The following is a description of a gene set: Genes down-regulated in comparison of untreated macrophages versus those cultured with M-CSF, IFNG and Pam3Cys (TLR2 agonist). Gene expression analysis of freshly isolated CD14+ human monocytes and monocytes cultured in the presence or absence of interferon (IFN) -gamma for 24 h and then stimulated with Pam3Cys, a Toll-like receptor (TLR) 2 ligand, for 6 h. Results provide insight into mechanisms by which IFN-gamma reprograms early macrophage differentiation and subsequent response to TLR ligands. Human Gene Set: GSE11864_UNTREATED_VS_CSF1_IFNG_PAM3CYS_IN_MAC_DN species: Homo sapiens from publication Hu X, Chung AY, Wu I, Foldi J, Chen J, Ji JD, Tateya T, Kang YJ, Han J, Gessler M, Kageyama R, Ivashkiv LB (PMID 18976936), and this is the list of marker genes: ISOC1, JPT2, CLDND1, MMAB, RBM19, ZNF175 (NCBI Gene Id 7728), DAD1, EDC4, NXT2, HAS1, FNDC3B, ACOX1, DOCK3, LYSMD2, NR2F2, ITPKC, BLZF1, IPO7, SPATS2L, RNF14, LRWD1, NUP188, RDX (radixin), RBM28, CDYL2, PGBD2, LRRC52-AS1, EXOC5, DESI2, POLR3C, GHITM, PRSS2, SERPINE1, HARBI1, PLEKHO1, TRRAP, AKT3, VPS33A, MTHFD1L, DLEU2 (deleted in lymphocytic leukemia 2), ZNF75A, SLC1A4, PIP5K1A, IST1, TRGV5, CLEC18A, BAZ1B, ZNF746, LRRTM1, NEXMIF, FJX1, FTL, L1CAM, HTR3B, POP7, GRIPAP1, STAM2, TMED1, ZNF227, QSOX2, PCDHB7, SNX9, FCGR1BP, MLF1, PMM2, PLEKHO2, PTPN21, ZNF506, CIAO2B, MED1, LY9 (lymphocyte antigen 9), ZNF804A, N4BP1, CPEB1-AS1, TRMT2A, AADACL2, EGLN2, TMEM248, CALU, RHOH, DISP2 (dispatched RND transporter family member 2), HCG4, DAB2, C4orf54, IRF2, TGS1, SLFN5, FIRRM (FIGNL1 interacting regulator of recombination and mitosis), SNRPG, HLA-A, SRP68, RNASEH1, TXLNA, NECTIN2, TLR8, ABCE1, TIMM10, PSMB2, HMGCR, GZMB, CTR9, YIPF4, VPS53, FAR1, CLN8, RAB40AL, ADAM9, LITATS1, UTP20, BIN3, TXNDC9, SDS, PLA2G4A, SCAMP3, ZFYVE16, ATP11A-AS1, PPM1B, NT5C1B, ASH2L, RAP2C, C21orf91, SRPRB, NOS1, PSMA1, GPR85, C3AR1, SLC11A2, LINC01845, ZNF302, SEC61G, LHX5, TNFSF11, GPR137B, GORASP2, UBB, TMEM41B, CD2BP2, VCX2, ENTPD7, DGKH (diacylglycerol kinase eta, NCBI Gene Id 8524), PNP, SLC35F5, PSMC6, PSMC2, PCBD1, IWS1, BRINP1, CBR4, CD180, TLR1, OR5P2, MYDGF, ZNF407, SETD4, SUGT1, BCL2L12, IL3RA, FPGS, GPR132, RNMT (NCBI Gene Id 8731), P4HA3, MED28, SEC61A1, SERF1A, SQSTM1, GDAP1, CYB5R1, INO80, DDX4, SLC30A6, GAPT, CHIC2, LIFR-AS1, COQ9 (coenzyme Q9), IKBKG, TINF2, SMG8, CSF1, PSMD13, RMI1, MACO1, RING1, IMMT (inner membrane mitochondrial protein), STK40, ATG101 (NCBI Gene Id 95005), HSPA9, PI4K2A, TDP2, ACP5, STX3, SRP54, KCTD17, STAG2, SPACA6, TERB1, RLN3, ANO5, ATF2, MTMR9